Given this list of marker genes LINC01623, PER3, LINC00431, STAT6, CASC3, ALOX12B, here is a description of the gene set: studied in species Homo sapiens Human Gene Set: ZNF416_TARGET_GENES from publication Yevshin I, Sharipov R, Kolmykov S, Kondrakhin Y, Kolpakov F (PMID 30445619) Genes containing one or more binding sites for (ZNF416) in their promoter regions (TSS -1000,+100 bp) as identified by GTRD version 20.06 ChIP-seq harmonization.